The following is a description of a gene set: studied in species Mus musculus Catalysis of the reaction: JNKK + ATP = JNKK phosphate + ADP. This reaction is the phosphorylation and activation of JUN kinase kinases (JNKKs). Mouse Gene Set: GOMF_JUN_KINASE_KINASE_KINASE_ACTIVITY, and this is the list of marker genes: Map3k7, Map3k1, Map3k11, Map3k20, Map3k5, Map3k14, Lrrk2, Map3k9, Map3k4 (mitogen-activated protein kinase kinase kinase 4), Map3k3 (mitogen-activated protein kinase kinase kinase 3), Map3k2, Map3k8, Map3k10, Ripk2, Map3k13, Map3k21, Map3k12, Map3k6, Ripk1, Map3k15